Given this list of marker genes Fgf23, Fgf20, Fgf2, Gipc1 (GIPC PDZ domain containing family, member 1), Fgf17, Fgf5, Fgf1, Fgf8, Fgfr1, Fgf6, Fgf4, here is a description of the gene set: electronically inferred by orthology from the curated human pathway species: Mus musculus This event has been computationally inferred from an event that has been demonstrated in another species.<p>The inference is based on the homology mapping from PANTHER. Briefly, reactions for which all involved PhysicalEntities (in input, output and catalyst) have a mapped orthologue/paralogue (for complexes at least 75% of components must have a mapping) are inferred to the other species. part of: FGFR1 ligand binding and activation Reactome Pathway: FGFR1c ligand binding and activation